The following is a description of a gene set: studied in species Homo sapiens PRL-JAK-STAT signaling pathway. Pathway ID: N00920. Pathway type: Reference. Pathway class: nt06325 PRL signaling. Pathway Definition from KEGG: PRL -> PRLR -> JAK2 -> STAT5 Human Gene Set: KEGG_MEDICUS_REFERENCE_PRL_JAK_STAT_SIGNALING_PATHWAY, and this is the list of marker genes: STAT5A, STAT5B, PRL, PRLR, JAK2 (Janus kinase 2)